The following is a description of a gene set: This event has been computationally inferred from an event that has been demonstrated in another species.<p>The inference is based on the homology mapping from PANTHER. Briefly, reactions for which all involved PhysicalEntities (in input, output and catalyst) have a mapped orthologue/paralogue (for complexes at least 75% of components must have a mapping) are inferred to the other species. part of: Intra-Golgi and retrograde Golgi-to-ER traffic electronically inferred by orthology from the curated human pathway studied in species Mus musculus Reactome Pathway: Golgi-to-ER retrograde transport, and this is the list of marker genes: Arfgap2, Pla2g6, Copb1, Kif1b, Bicd2, Nbas, Klc3, Racgap1, Kif18b, Kif3c, Kif2b, Dctn1, Tmed9, Nsf, Rab6a, Rint1, Galnt1, Copg2, Copb2, Kdelr1, Cenpe, Tubb4a, Kif9, Pafah1b3, Tuba8, Tmed3, Rab1b, Agpat3 (NCBI Gene Id 28169), Tuba1a, Klc4 (NCBI Gene Id 74764), Tuba4a, Tuba3b, Dync1li2, Actr1a, Rab18 (RAB18, member RAS oncogene family), Kif5b, Kif12, Kdelr2, Arcn1, Kifap3, Tubal3, Tuba1c, Kif20a, Kdelr3, Kif27, Tubb2b, Dctn6, Tubb6, Rab3gap2, Arf5, Tubb4b, Tuba1b, Arf1, Tmed10, Dynll1, Kif26a, Kif21a, Rab1a, Stx18, Kif2c, Actr10, Copg1